Given this list of marker genes ZPR1, MLYCD, GPR65, FAM98B, SNHG3, C4orf36, DENND2C, MTHFD2, DUSP4, NR4A3, CD69, RBSN, C17orf100, EXOSC3, YRDC, DNAJB9, NAA30, ENPEP, MLH3, TAGAP, TMEM243, VCAM1, PTRH2, BTG2, H4C4, SNAPC1, RABIF, ZNF256, BCLAF3, TP53RK, SELENOK, DUSP2, OSBPL1A, ZCCHC13, PLPP1, PPAN, PIK3CB, SI, ZNF410, LINC00290, FEN1, FBXO33, AP5S1, ETV3, SLC31A1, PRPF38A, PPM1D, ZFP30, IER2, ZBTB10, DLGAP1-AS3, NFKBID, EQTN, SLC2A3, KBTBD8, MIR21, SELENOS, FAM98A, ZNF569, PALM, MRPS18A, ADO, SH3RF3-AS1, ITGA3, MBNL2 (NCBI Gene Id 55479), CPB1, VTI1B, PRSS12, BCL10, PUS3, NR4A2, LINC00115, CHAC2, EGR1, TNFRSF11B, PDCL, HSF5, E2F6, TRMT10C, PTGR2, FUT4, MIR17HG, ZNF571, DNAJB4, CREM, ZNF331, TNF, ZNF415, GPR18 (NCBI Gene Id 2841), SPICE1, NR4A1, C2orf69, VPREB3, MRPL42, C11orf97, ZNF227, PHLDA1, FAM220A, RBPJL, RASGEF1B, ZNF143-AS1, GMNN, MYNN, PWWP2B, ZNF850, JAGN1, FYCO1 (NCBI Gene Id 79687), KIAA1586, WDR33, KPNA2, DNM3, MED21, S1PR1, PLXND1, NUDT15, CSTF2T, IER5, IBA57, SNRNP35, CKS2, CCDC141, SPRY1, NTMT1, YIPF4, TIMELESS, ZFP82, PLEKHG7, CNTNAP1, EGR3, ARL5B, SMIM7, FAM200A, ATG101, TEX47, NFE2L2, ZBTB8A, BIRC3, ITIH3, CRNKL1, STK36, TCAF1, TXNRD1, SESN3, GGACT, NCBP1, ARL9, NFE4, EVI2A, CYP51A1, MOCS2-DT, PFKFB3, GEM (GTP binding protein overexpressed in skeletal muscle), CCNH, C6orf120, EGR2, LMBRD2, DNAJB6, PNPLA8, TXNDC15, ALG13, TLR1, ENPP2, CYCS, GPR183, CENPL, BCL2A1, LPAR6, ZNF701, BTN2A2, MEIG1, MCPH1 (NCBI Gene Id 79648), GET1, NR1I3, ISG20L2, ANKRD37, RNF113A, BCOR, HCP5, SRSF1 (NCBI Gene Id 650453), TBX15, FNIP1, ZNF184, CYTIP, TIGAR, FBXO30 (NCBI Gene Id 84085), ZBTB3, SH2D5, ZNF200, KLHL18, ELOVL4, here is a description of the gene set: Human Gene Set: GSE17974_CTRL_VS_ACT_IL4_AND_ANTI_IL12_0.5H_CD4_TCELL_DN The aim of this dataset was to study in detail the transcription kinetics initiated by cytokine IL-4 in early differentiation of Th2 cells. from publication Elo LL, Järvenpää H, Tuomela S, Raghav S, Ahlfors H, Laurila K, Gupta B, Lund RJ, Tahvanainen J, Hawkins RD, Oresic M, Lähdesmäki H, Rasool O, Rao KV, Aittokallio T, Lahesmaa R (PMID 20620947) Genes down-regulated in comparison of untreated CD4 T cells at 0 h versus the cells treated with IL4 and anti-IL12 at 0.5 h. studied in species Homo sapiens